Given this list of marker genes Cyp4f40, Fgf23, Cbr3, Pdxp, Cyp26b1, Klf9 (NCBI Gene Id 70273), Cyp26a1, Cyp2w1, Strap, Sp1, Cyp27b1, Cyp26c1, Cubn (cubilin), Cyp24a1, Pm20d2 (NCBI Gene Id 242377), Mthfsl, here is a description of the gene set: studied in species Mus musculus Mouse Gene Set: GOBP_VITAMIN_CATABOLIC_PROCESS The chemical reactions and pathways resulting in the breakdown of a vitamin, one of a number of unrelated organic substances that occur in many foods in small amounts and that are necessary in trace amounts for the normal metabolic functioning of the body, carried out by individual cells.